The following is a description of a gene set: Genes up-regulated in CD8 T cells during chronic infection with LCMV-Clone 13: effectors at day 8 versus exhausted at day 30. During acute viral infections, naïve CD8+ T cells differentiate into effector CD8+ T cells and, after viral control, into memory CD8+ T cells. Memory CD8+ T cells are highly functional, proliferate rapidly upon reinfection and persist long-term without antigen. In contrast, during chronic infections, CD8+ T cells become “exhausted” and have poor effector function, express multiple inhibitory receptors, possess low proliferative capacity, and cannot persist without antigen. To compare the development of functional memory T cells with poorly functional exhausted T cells, we generated longitudinal transcriptional profiles for each. species: Homo sapiens from publication Doering TA, Crawford A, Angelosanto JM, Paley MA, Ziegler CG, Wherry EJ (PMID 23159438) Human Gene Set: GSE41867_DAY8_EFFECTOR_VS_DAY30_EXHAUSTED_CD8_TCELL_LCMV_CLONE13_UP, and this is the list of marker genes: TYMS, SLC25A6, PSMB4, AMZ2, SPTY2D1, SELENOK, TRAPPC2B, PDCD1, CAD, TMEM263, PCBP1, EIF1AD, RRM1, UQCR11, SVIL, PLK4, SRM, RFFL, NTN5, SEC11C, MPHOSPH6, ITPKA, EDEM1, TRPS1, OXSR1, BLOC1S5, ADD1, PPT1, MGAT1, EIF5A, MGST1, TESC, SUN1, TBC1D10B (NCBI Gene Id 26000), AHNAK, KANK2, COPA, PLEKHA1, ADGRL2, SAPCD2, SUV39H1, PPIA, MYD88, NIBAN3, FER, MT1E, CNIH4, RAB11A, PKNOX1, PAQR3, MIA3, HSF2, TACC2, TSPAN5, BIRC5, TM9SF1, CALU, PCGF3, STOML2, MTOR, EBP, DUSP12, NUDCD3, PLXNC1, MRPS6, ACY1, CTNNA1, CYB5R3, IQGAP3, HACD2, EIF2AK3, MAF, UBXN2B, CNEP1R1, NDUFB6, DOP1B (DOP1 leucine zipper like protein B), MRPS22, CEP290, SHCBP1, PIGF, TTLL12, MED17, PACS2 (phosphofurin acidic cluster sorting protein 2), FAM241A, HSPA5, PGGHG, WEE1, CUTA, MED8, SEC63, GPN3, LYAR (NCBI Gene Id 55646), TVP23B, RPN2, ACTN1, BATF3, MED9, MORF4L2, EIF4G1, SLC35A2 (solute carrier family 35 member A2), DDX24, IGHM, ARID3A (NCBI Gene Id 1820), WDR13, CAPN7, CKAP2, CCNC, MESD, NT5DC3, SRSF7, ORC1, TUBA1B, USP47, PRAF2, EML5, EEF1E1, BET1, WDR3, SRSF9, RAB1A, NEMP1, ERGIC1, MSI2 (musashi RNA binding protein 2), EZH2, UNC119B, DMD, NDUFA4, CGRRF1, PTPRJ, B3GAT3, ADK, ABHD11, AKAP1, PTTG1 (NCBI Gene Id 9232), DHRS13, AATF, CEP83, NINJ1, NFKBIB, ITGB1, COPS3, NUTF2, SLC7A6, HADHB (hydroxyacyl-CoA dehydrogenase trifunctional multienzyme complex subunit beta), BTAF1, ALDH7A1, UBAC2, TNFRSF18 (NCBI Gene Id 8784), TMEM165, ABCF1, MED12, GUSB, TRIM25, SLC7A6OS, PIN1, TIMM8B (NCBI Gene Id 91900), RFNG, G3BP2 (G3BP stress granule assembly factor 2), SLC19A2, ALYREF, MICOS10, PRDX5, SPC24 (NCBI Gene Id 147841), ECI2, CTSB, BCKDK, ATP5MG, PHRF1, PLEKHH3, PRR11, CDK16, POC5, ENTPD1, EIF2B3, CD5L, REEP4, SEC11A, HES1, LRRC8A, HMOX2, EVC2 (NCBI Gene Id 132884), JMJD8, SLC35E2B, TUBB6, NINJ2, ENC1, RBX1, NUP85, LYSMD3, SND1, MEGF8, PPP1R2P1, GPHN, COX7A1, MRPL42, EXOSC10, CRIM1, ATP6AP2, TMEM150A